Given this list of marker genes Casp4, Gsdme, Gsdmd, Gzma, Ninj1, here is a description of the gene set: studied in species Mus musculus A inflammatory cell death process associated with the generation of pyrogenic mediators that result from the activation of gasdermins. Mouse Gene Set: GOBP_PYROPTOTIC_CELL_DEATH